Given this list of marker genes Trmt5, Nop2, Nsun2, Tfb1m, Mto1, Fbll1, Mrm3, Mettl5, Tfb2m, Fdxacb1, Dimt1, Trmt13, Mettl2, Mettl16, Trmt10a, Thada, Mettl3, Mettl8, Trmt6, Trmt44, Trmt112, Nsun4, Trmt2b, Thumpd2, Ramac, Henmt1, Trdmt1, Dalrd3, Larp7-ps, Mrm1, Rnmt, Rbm15b, Rbm15, Trmo, Bcdin3d, Gtpbp3, Mettl14, Thumpd3, Nsun5, Tgs1, Wdr4, Mettl6 (NCBI Gene Id 67011), Trmt1l, Mepce, Ftsj3, Tarbp1, Mettl1, Emg1, Nsun3, Alkbh8, Trmt10c, Fbl, Hsd17b10, Trmt12, Lcmt2, Mrm2, Akt1, Trmt1, Bud23, Tyw3, Ftsj1, Nsun6, Trmt61a, Zcchc4 (zinc finger, CCHC domain containing 4), Trmt10b, Trmt9b, Larp7, Wdr6, Mettl15, here is a description of the gene set: Mouse Gene Set: GOBP_RNA_METHYLATION Posttranscriptional addition of a methyl group to either a nucleotide or 2'-O ribose in a polyribonucleotide. Usually uses S-adenosylmethionine as a cofactor. species: Mus musculus